The following is a description of a gene set: Genes up-regulated in monocytes isolated from peripheral blood samples of Sezary syndrom patients compared to those from healthy normal donors. species: Homo sapiens PURPOSE: Increased production of Th2 cytokines characterizes Sezary syndrome, the leukemic form of cutaneous T-cell lymphomas (CTCL). To identify the molecular background and to study whether shared by the most common CTCL subtype, mycosis fungoides, we analyzed the gene expression profiles in both subtypes. EXPERIMENTAL DESIGN: Freshly isolated cells from 30 samples, representing skin, blood, and enriched CD4(+) cell populations of mycosis fungoides and Sezary syndrome, were analyzed with Affymetrix (Santa Clara, CA) oligonucleotide microarrays, quantitative PCR, or immunohistochemistry. The gene expression profiles were combined with findings of comparative genomic hybridization of the same samples to identify chromosomal changes affecting the aberrant gene expression. RESULTS: We identified a set of Th1-specific genes to be down-regulated in Sezary syndrome as well as in a proportion of mycosis fungoides samples. In both Sezary syndrome and mycosis fungoides blood samples, the S100P and LIR9 gene expression was up-regulated. In lesional skin, IL7R and CD52 were up-regulated. Integration of comparative genomic hybridization and transcriptomic data identified chromosome arms 1q, 3p, 3q, 4q, 12q, 16p, and 16q as likely targets for new CTCL-associated gene aberrations. CONCLUSIONS: Our findings revealed several new genes involved in CTCL pathogenesis and potential therapeutic targets. Down-regulation of a set of genes involved in Th1 polarization, including the major Th1-polarizing factor, TBX21, was for the first time associated with CTCL. In addition, a plausible explanation for the proliferative response of CTCL cells to locally produced interleukin-7 was revealed. from publication Hahtola S, Tuomela S, Elo L, Häkkinen T, Karenko L, Nedoszytko B, Heikkilä H, Saarialho-Kere U, Roszkiewicz J, Aittokallio T, Lahesmaa R, Ranki A (PMID 16914566) Human Gene Set: HAHTOLA_SEZARY_SYNDROM_UP, and this is the list of marker genes: MTX1, RGCC, FAS, PRDX4, SLC25A37, PTTG1, RECQL, RNASE2, SNCA, PSMB3, H1-2, REXO2, NINJ2, H2AC18, CRIP1, SELENBP1, SAMSN1, ARMT1, TRAT1, HP, GPR171, EZH2, CA1, RNF125, TRIB1, NBN, BARD1, PNP, GSPT1, MEOX1, MMP9, CDK7, PDXK, SMC4, NTAN1, GOLGB1, ITM2A, THOC5, HBA1, CSGALNACT1, EIF1AY, CES1, ALAS2, IMPA2, C3AR1, IDS, KTN1, ZC2HC1A, TFDP1, MS4A4A, UBXN4, FAR2, LILRA5, PSMB2, GLUL, PRC1, BAZ1A, HAT1, IL10RB, TOP1, RRM2, NFE2, LIMK2, TYMS, ACTR1A, STAT1, DYSF, SH3GLB1, F5, TLR1, RAD51C, WAPL, ETHE1, NPIPB3, LPAR6, CD55, S100A12, GLIPR1, HBD (hemoglobin subunit delta, NCBI Gene Id 3045), LGALS8, JPT1, NMT1, IL2RA, CD28, TNFSF10, TJP2, IQGAP1, RBM25, NCF4, RTCA, ICOS, NUSAP1, PAPSS1, NIBAN1, HBB, CCR10, PGD, CKS2, S100P